The following is a description of a gene set: Human Gene Set: HP_ABNORMAL_CIRCULATING_POTASSIUM_CONCENTRATION Abnormal circulating potassium concentration species: Homo sapiens An abnormal concentration of potassium., and this is the list of marker genes: SLC34A1, SLC12A1, SLC2A1, SNTA1, TERT, SCN4A, PBX1, CALM2 (calmodulin 2), ALDOA, CACNA1C, NFKB2, TBX19, ANK2, POR, NR0B1, KCNE2, GATM, CA12, CYP11B2, SLC2A2, SCNN1A, AIP, KLHL3, ZNRF3, SEC61A1, CLCN2, USP8, GEMIN4, AKAP9, KCNQ1, KCNN4, OCRL, NUP214, SLC30A9, WNK4, KCNE1, SCNN1G, SLC4A2, NNT, RYR1, SLC12A3, INVS, POLG2, KCNJ5, HSD11B2, CACNA1D, TP53, BSND, CALM3, PRKAR1A, SCN4B, TBX5, NOS1AP, MT-CO1, CYP11B1, CLCNKB, MC2R, CALM1 (calmodulin 1), KCNJ10, NR3C2, INSR, SMAD4, MAGED2 (NCBI Gene Id 10916), NR3C1, SCN10A, SCN5A, SLC26A3, UNC45A, CLCNKA, CASR, GABRA3, KCNJ2, KCNJ1, WNK1, FXYD2, TRDN, ATP1A1, OBSCN, RRAGD, SERPINA6, KCNE3, KCNJ18, PIEZO1, CLDN10, ATP6V0A4, ABCB6, CACNA1S, CTNS, MT-CO3, CTNNB1, CUL3, COL3A1, CDH23, KCNH2, NDUFAF6, SCNN1B, LPIN1, EHHADH, PKD2, DEF6, MRAP, PAX2, CDKN2A, SLC4A4, ASL, BMPR1A, SLC4A1, CAV3, TXNRD2, HSD3B2, CYP17A1, SAMD9 (sterile alpha motif domain containing 9), CYP11A1, STAR